The following is a description of a gene set: Human Gene Set: GOMF_PROTEIN_KINASE_A_CATALYTIC_SUBUNIT_BINDING Binding to one or both of the catalytic subunits of protein kinase A. studied in species Homo sapiens, and this is the list of marker genes: PRKAR2B, GSK3B, PJA2, SMO, KCNQ1, GSK3A, PRKAR2A, PRKAR1A, PRKAR1B, SOX9, EZR, CSK, RYR2, PKIA